Given this list of marker genes FOXP3, RIPK3, PDCD1LG2, TYK2, HLA-DPB1, INHA, IL27RA, CD274 (NCBI Gene Id 29126), LTA, KLRC4-KLRK1, CD3E, WNT5A (NCBI Gene Id 7474), DDIT3, HMHB1, EBI3, RARA, LILRB4, MIR24-1, LGALS9B, SCRIB (scribble planar cell polarity protein), ARID5A, TNFSF4, IL18R1, HSPD1, SLAMF6, CD96, TLR8, GATA3, XCL1, ZP3, PGLYRP1, SCGB1A1, KLRK1, CYRIB, ZNF683, TLR3, PDE4B, IL36RN, CD226 (NCBI Gene Id 10666), CD276, CRTAM, ZFPM1, LGALS9, ZC3H12A, IL21, HMGB1, HRAS, TNF, IL12A, IL20RB, PGLYRP2, GAS6 (growth arrest specific 6), PTPN22, NR1H4, TLR7, CD2, IL1RL1, LGALS9C, IL1B, IL1R1, IL12B, ISL1, SLC7A5, UFC1, F2RL1, LAPTM5, IFNL1, CR1, NLRP6, BCL3, CLEC7A, RIPK2, JAK2 (NCBI Gene Id 3717), CD47, CCR7, IL27, LILRB1, PDE4D, IL23A, MIR708, ISG15, SLAMF1, IL10, FADD, HLA-DRB1, CEBPG, ABL1, CD14, TRIM27, TLR9, HMSD, HLA-A, IL23R, IL2, PRNP, CCR2, IRGM, CD160, IL12RB2, C1QBP, HLA-DPA1, SIRPA, BTN3A2 (NCBI Gene Id 11118), PYCARD, IL18, TXK, INHBA, AXL, IL33, APP, IRF8, UFSP2 (NCBI Gene Id 55325, UFM1 specific peptidase 2), HAVCR2, SLC11A1, PGLYRP3, BTN3A1, VSIR, FZD5, CD244, TLR4, SASH3, IL12RB1, UBA5, here is a description of the gene set: The appearance of interferon-gamma due to biosynthesis or secretion following a cellular stimulus, resulting in an increase in its intracellular or extracellular levels. Interferon-gamma is also known as type II interferon. studied in species Homo sapiens Human Gene Set: GOBP_TYPE_II_INTERFERON_PRODUCTION